Given this list of marker genes KLHL36, STK4 (serine/threonine kinase 4), RSBN1, PIEZO2, YWHAB, SUV39H2, HCCS (holocytochrome c synthase), HOXB2, SOX6, LRRTM1 (leucine rich repeat transmembrane neuronal 1), USP33, SECISBP2L, BCL11B, TGFBR2, NCOA3, MPHOSPH9, ZSCAN23, LIN28B, ADNP2, RAB11FIP2, PELI1, MEOX2, INSR, LYN, HOMER2, RASGRP3, RBM41, GATA6, NDST3, ERBB3, PXN, HIF3A, SLC27A4, PTGR3, PCTP, SETMAR, JOSD1, UBR3, NEURL1B, PLXNA2, ITGAL, ZNF664, PTPRO (protein tyrosine phosphatase receptor type O), MEIOC, KLC4, TENT4B, BICD2, TANC2, SLC9A3, CEBPG (CCAAT enhancer binding protein gamma), HOOK3, IBSP, SOX30, PLXNA4, RPS6KL1, PIP4P2, ACTB, PTPN2, NUTM2G, KLHL9, DPP4, DESI2, L3MBTL4, ZNF717, PAN3, GLT8D1, SRD5A3, ZNF646, CLCN5, ILDR1, LAD1, PTPN7, CHIC1, GALNT6, CACUL1, PITPNC1, PLRG1, PBX2 (NCBI Gene Id 5089), TRERF1, TRPV5, CDH4, IL25, KIF16B, SCN4A, IRS1, SHISAL1, ZNF805 (zinc finger protein 805), UHRF2, STAC2, NRIP1, ZNF264, CASP6, ZNF48, IGDCC3, MORN5, SLC35G1, HTR7, ERMP1, APTX, POMGNT1, TNRC6C, PSEN1, ABCC9, DNAJC27, DLX3, NPC1, ACTL6A, POTEE, CTAGE6, CNPY1, ZNF609, ZNF451, ANO3, SLC39A8, PUS10, WIPF3, RRP15, THRB, HNF4G, DIXDC1 (DIX domain containing 1), C11orf54, SBNO2, TRNP1, RELN, PDE4D, RPS6KA6, IPCEF1, MTCP1, PPP1R9A, BMP2, CTBP2, APOO, TOMM40L, DHX35, FBXL3, NAA15, FBN3, SOX11, ZNF397, HTT, ADAM10, ZXDC, RP2, NPR3 (NCBI Gene Id 79614), BBC3, GABRA5, FAM53B, KLF13, LOXL4 (NCBI Gene Id 84171), TTBK1, SLCO2B1, ZZEF1, WASHC4, ATP11C, PLPPR5, CTBP1, CAPN15, GRAMD2B, LDB2, SLC7A11, INTS14, UNC80, SRC, SP1, NATD1, DNMBP, OTUD3, RBBP5, CD300LD-AS1, ZRANB1, COL21A1, POLR3G, TMEM154, AMMECR1L, PKN2, EPB41, CBX2, RASSF5, BLTP3A, ZIC3, SOX12, KCTD15, NR4A3, POC1B, ABRACL, NRN1, FNTB, FOXK1, ETS1, RPL13, UGT3A1 (NCBI Gene Id 133688), MICOS10, HOMER1, NUCKS1, EML4, TMEM121 (NCBI Gene Id 80757), IRF2, PDE6B, TTC28, COL24A1, PCDH17 (NCBI Gene Id 27253), TRIM9, TLN2, PTK2 (NCBI Gene Id 5747), ZSWIM4, UST, SGSM3, ABCG2, ABI2, NFAT5, ALG9, IDE, CREB1, DYRK2, UBN2, FEN1, OGFRL1, VANGL1, ASXL2, SEMA5A, EIF4EBP2, DOCK9, THUMPD1, FIGN, RBM7, CHFR, UBE3A, HCK, OSBPL8, ARPP19, POLE3, MCFD2, GTF2A1, MPLKIP, GTF2H1, CTAGE15, TFDP2, ISCU, SRRM4, TMEM41B, RCE1, KLF3, LRRC15 (NCBI Gene Id 131578), LYSET, HPGD, USP13, TNRC6B, LCN10, IKZF2, H2AZ1, ELMOD2, TRIL, CAND2, BRMS1L, CLCF1, MTDH, EML1, C17orf75, CYB5R4, GMCL1, BTC, TMX1, FAM107B, PPP1R12B, ARL15, GRIA4, LIN28A, SLC24A2, CRELD1, MIA2, JAKMIP3, CCDC117, BACH2, CCDC62, SLC11A2 (NCBI Gene Id 4891), FGFR1OP2, CIAO2A, PPM1E, MYCBP2, SLCO2A1, ACSL6, HAPLN4, LIMD1, MPPED1 (NCBI Gene Id 758), BEND4, IRX2, TSPAN9, THPO, CAMSAP2, LRRC8E, ELAPOR2, APPBP2, SLC2A12, CDCA7L, TRIM44, UNC5D, CUL1, PDE3B, SLAIN2, IPMK, AJUBA, ZNF516, LMCD1, LATS2, MYT1, ZNF281 (NCBI Gene Id 23528), CREM, ATG2B, ENDOV, MED22, DOCK11, DIO2, LPP, MAP3K1, MBTD1, SLC14A1, ALDH1A2, VGLL3, BNC1, BDP1, HDX, JAKMIP2, DEDD2, PAQR8, ARHGEF39, AP4E1, MTERF1, DGKE, COCH, CPNE5, USP12, TMEM64, ABCC5, here is a description of the gene set: Genes predicted to be targets of miRBase v22 microRNA hsa-miR-1200 in miRDB v6.0 with MirTarget v4 prediction scores > 80 (high confidence targets). from publication Chen Y, Wang X (PMID 31504780) studied in species Homo sapiens Human Gene Set: MIR1200